Given this list of marker genes AR, CCL21, NCOA4, FBP1, SFRP1, SCNN1D, GOLPH3, TFAP4, KLF9, SMYD3, ACACA, CCR7, P2RY4, GNB1, BMI1, ADCY5, SOX10, MIR342, MSN, ADCY3, PCK1, FOXO3, KLF4, RPS6KB1, PRKAA2, SGK1, KLF2 (KLF transcription factor 2), SIRT1, PRKAA1, SPHK2, TNFSF4, METTL21C, TBX2, USP8, AHR, DEFB104B, RWDD1, GNAS, CFLAR (CASP8 and FADD like apoptosis regulator), ROCK2, POSTN, ADCY8, ABCB1, FOS, SCNN1G, TNC, TGFB1, FECH, SCNN1A, BTG2, ASS1, MAP4K1, GNG2, DEFB104A, GAS6, FDX1, P2RY6, CBX3, AQP1, SP1, PIM3, EFNA5 (NCBI Gene Id 1946), DDIT4, FBXO32, ELK1, AIFM1, SRD5A1, CRH, UGT3A2, ADCY6, CDK4, MSTN, EIF4E, SLC5A5, PRKCE, SLC39A9, NPAS4, CASP9, TRERF1, AKT1, AKAP8, HCN2, NCF1, CREB1, PTGDR2, SERPINF1, PRKD1, SCNN1B, AKR1C3, UCP1, CFTR, SPP1, PTGER2, PTGDR, PTGER4, ADCY1, ANKRD13C, SRC, JAK2, GNAI1, PTGFR, XRN1, VPS54, PCK2, CCL19, NR3C1, ADAM15, PARK7, AKR1C2, ERRFI1, ADCY2, LARP1, ACOD1 (NCBI Gene Id 730803), AXIN2 (axin 2), ATP5F1A, here is a description of the gene set: species: Homo sapiens Any process that results in a change in state or activity of a cell (in terms of movement, secretion, enzyme production, gene expression, etc.) as a result of a ketone stimulus. Human Gene Set: GOBP_CELLULAR_RESPONSE_TO_KETONE